The following is a description of a gene set: studied in species Homo sapiens Human Gene Set: WP_INTERACTIONS_OF_NATURAL_KILLER_CELLS_IN_PANCREATIC_CANCER Interactions of natural killer cells in pancreatic cancer, and this is the list of marker genes: ADAM17, MICB, KLRK1, PVR, CSF2, NCR1, PRF1, CCL3, FOXO1, MYC, BMI1, NCR3, CCL4, NCR3LG1 (NCBI Gene Id 374383), GATA2, IFNG, KLRC4-KLRK1, GZMB, MICA, CCL5, CCL2, CCL1, ADAM10, CD96, CD226 (NCBI Gene Id 10666), TIGIT, FCGR3A, TNF